Given this list of marker genes CASP9, NFIB, FCHSD2, XBP1, EIF4E2, TICAM1, RPL4, CDK18, NAB1, RAB14, LRP8, SPINT2, ELL2, SYK, EIF4A1, PPIB, FUCA1, SOCS1, PSMG1, TMED2, TUBB2B, HS3ST1, POLR1HASP, CEACAM8, TSFM, RHOH, NDUFV2, MAPKAPK3, CCT4, MAGEA11, HLA-DMB, MADCAM1, RCHY1, GORASP1, CD63, MYRF, SLC43A1 (NCBI Gene Id 8501), HINT1, XPA, TNFAIP8, HSPE1, CD69, EZH2, TMF1, PXDC1, CITED2, CDKN1A, CSF2RB, SEL1L, HLA-DRA, PDE4B, FCGR2B, RAMP3, CCND2, RPL8, SNX3, FRMD4B, OLR1, IVNS1ABP, TNKS, SFT2D2, LTA4H, EDEM1, PITRM1 (pitrilysin metallopeptidase 1), ALOX5, LEPR, IFNA5, PER2, ENO1, SUPV3L1, VHL (NCBI Gene Id 8056), MED20, NDRG1, LTB, CD24, SPINK1, PAMR1, PLEKHB2, LYRM1, EIF3D, PSMA6, AP3S2, TGDS, ETS2 (NCBI Gene Id 2114), CCNE2 (cyclin E2), STAT4, NASP, PAK2, HIF1A, CD44, TRA2A, CD3G, TCOF1, EIF3B, IL1RN (interleukin 1 receptor antagonist), COX7A2L, RNMT, KRT12, CTSH, BYSL, STX7, CDK5R2 (NCBI Gene Id 8941), CRYBG1, ITGAX, HBEGF, NPC1, ZNF124, CYRIA, N4BP1, DLX5, ABR, GNAZ, LSM7, GPR65, IDI1, ABCF1, KDR, EBNA1BP2, PAK5, ARL6IP5 (NCBI Gene Id 10550), HNRNPAB (NCBI Gene Id 3182), SNU13, IL2RB, CEP170, TPD52, CXCR5, CD53, SPHK2, LRPAP1, PUM3, TIMM44, DCX, ZBTB24, ALOX5AP, SLC11A2 (NCBI Gene Id 4891), ZNF101, ANP32B, TPT1, ZNF592, FARSA, NKG7, ATP6V1C1, LRIG1, POLA2 (NCBI Gene Id 23649), UBFD1, ARNT2, PRKX, IGFBP4, BHLHE40, PRNP, OPCML, QSOX1, TNF, TUBB, BPI, GPAA1, FAM13A, LCP2, DCAF11, MCAT, PIM1, CDH3, CYB561D2, BGN, RAD23A, CYP11B1, CD300A, FLOT1, HSPH1, TMED9, BCL9, HCAR3, RCBTB2, SLC20A2, LHFPL2, NPAS2, DDX42 (DEAD-box helicase 42), DUSP5, CEACAM1, LAIR2, ATXN1, ASMTL, ARAP2, SCARF1, ATP1B3, ABCC8, PPP1R3C, PLCG2, FAM13C, EDN2, SRGAP2, CDO1, SEC14L1, STK10, NUBP1, AVPR2, RYR1, PREP, here is a description of the gene set: studied in species Homo sapiens Human Gene Set: GSE2770_UNTREATED_VS_TGFB_AND_IL4_TREATED_ACT_CD4_TCELL_48H_DN Th1 and Th2 cells arise from a common precursor cell in response to triggering through the TCR and cytokine receptors for IL-12 or IL-4. This leads to activation of complex signaling pathways, which are not known in detail. Disturbances in the balance between type 1 and type 2 responses can lead to certain immune-mediated diseases. Thus, it is important to understand how Th1 and Th2 cells are generated. To clarify the mechanisms as to how IL-12 and IL-4 induce Th1 and Th2 differentiation and how TGF-beta can inhibit this process, we have used oligonucleotide arrays to examine the early polarization of Th1 and Th2 cells in the presence and absence of TGF-beta after 0, 2, 6 and 48 hours of polarization. Genes down-regulated in CD4 T cells: untreated (0h) versus activated by anti-CD3 and anti-CD28 and then stimulated by TGFB1 and IL4 (48h). from publication Lund R, Aittokallio T, Nevalainen O, Lahesmaa R (PMID 14607935)